Given this list of marker genes Syp, Gabrg2, Pax8, Mir26a-2, Cacna1e, Lnpep, Bmp6, Ywhaz, Dab2, Hes1, Rbm4, Chrnd, Glra2, Mir125b-1, Slc16a2, Cck, Tshz3, Mir153, Entpd1, Mir15a, Cyp46a1, Syt6, Tenm2, Gria2, Oxct1, Pdlim4, Agtr1a, Ophn1, Lypd1, Agtr2, Pde4a, Cdh2, Plcd1, Midn, Shank3, Grm1, Sytl4, Slc12a5, Fcer1a, Hnf4a, Rasgrf1, Gata3, Mir301b, Mir28a, P2rx7, Cacna2d1, Dlg3, Ghrh, Myb, Wnt7a, Wnt5b, Lgals3, Lyn, Fkbp1b, Egfr, Cacna1a, Insyn1, Dgat1, Syngr3, Mup2, Gpr158, Agrn, Lin7c, Dvl1, Asic1, Lrp5, Prkce (protein kinase C, epsilon), Tbc1d1, Snap47, Hrh2, Slc30a8, Selenom, Lrfn2, Gabrg1, Mir501, Gdf9, Mir667, Pacsin2, Rims4, Btk, Ptpn23, Tbx3 (T-box 3), Ncoa6, Gata1, Homer3, Pink1, Synpo, Dkk1, Tacr1, Gprin3, Sncg (NCBI Gene Id 30871), Ptprn (NCBI Gene Id 19275), Psca, Sh3gl1, Igfbp3, Mir204, Bsn, Nr4a1, Dlgap4, Rnf167, Atp5pf, Nadk, Pirb (NCBI Gene Id 18733), Mir125b-2, Lrp1, Gal, Cacnb1, Hip1, Drd5, Fxr1 (FMR1 autosomal homolog 1), Plcb4, Arrb2, Rab11fip1 (RAB11 family interacting protein 1 (class I)), Apba1, Clock, Jagn1, Mir328, Abi1 (NCBI Gene Id 214715), Cdc20, Vip, Slc6a4, Brsk2 (NCBI Gene Id 75770), Cspg5, Gabrr1, Nxph4, Pde1c, Efnb3, Mir26a-1, Efna5, Crhbp, Ptprn2, Mafa, Hfe, Plcl1, Npy, Ren1 (renin 1 structural), Fgfr2, Slc1a1, Dlgap1, Kcnj6, Lrrk2, Il1rn, Mir872, Kat2a, Napb, Mir30e, Itpr1, Best1, Tac1, Afdn, Arid1b, Fam3b, Cpeb3 (cytoplasmic polyadenylation element binding protein 3), Gpr151, Cxcl12, Cacng3, Chrna1, Kcnq3, Zdhhc12, Micu3, Ptpn11, Cit, Fgfbp1, Cav2, Mir22, Gucy1a1, Foxo1 (NCBI Gene Id 99758), Stab1, Chrna4, Acvr2b, Rptor (regulatory associated protein of MTOR, complex 1), Chrm1, Gsk3b, Gja4, Cacna1c, Prrt2 (NCBI Gene Id 69017), Eif4ebp2, Creb1, Lama2, Map2k6 (mitogen-activated protein kinase kinase 6), Sirt3 (sirtuin 3), Cep89, Gna11, Snx19, Ly6g6e, Npy2r, Ank2, Vdac3, Atf4, Nrn1, Atxn1, Mir875, Stac3, Ly6g2, Anxa5, Ly6c1, Pdyn, Nkx6-1, Stxbp2, Plppr4, Nxph1, Bmp2, Slc29a1, Trim9, Oprk1, Usp8, Hcar2, Rfx3 (NCBI Gene Id 320548), Grm7, Zbed6, Slc6a5, Nrxn3, Chrnb2, Cacng7, Blk, Mir129-2, Stx1b, Pomc, Irs1, Drp2, Ptpra, Nat8l, Sirt4, Hnrnpk, Mir30b, Zzef1, Gls, Cbln4, Git1, Kcnma1, Mir30d, Ezh2, Chd7, Lhx5, Rnf10, Grik2, Stau2, Stxbp1, Drd1, Abl1, Syngr1, Pfkfb2, Htr1f, Stx4a, Adora1, Ntsr1, P2rx2, Fbxl20, Gabrg3 (gamma-aminobutyric acid type A receptor, subunit gamma 3), Gnaz, Mir124-2hg, Gabrr2, Shisa9, Mir384, Mecp2, Tbx5, Faah, Stxbp3 (syntaxin binding protein 3), Fjx1, Bhlha15, Rap1a, Ghsr, Slc16a1, Slc16a10, Htr5a, Cyp19a1, Chrna7 (cholinergic receptor, nicotinic, alpha polypeptide 7), Snapin, Mir187, Cask (NCBI Gene Id 236691), Gja1, Hmga1, Slc24a1, Lrp6, Ly6f, Pde9a, Nppa, Neto1, Lif, Gip, Vps35, Stx19, Ephb1, Lin7b, Nptn, Chrm2, Trpv6, Adra1b, Barx1, Kif1b, Cntn2, C1qtnf12, Notch1, Mir484, Cxcl13, Tmod2, Clstn1, Slc25a22, Gabrb3, Rab8a, Cyp27b1, Cdh8 (cadherin 8), Rims3, Bcr, Mir138-1, Pask, Gjc2, Tmem108 (NCBI Gene Id 81907), Gpr68, Penk, Mir19b-1, Syt9 (synaptotagmin IX), Ptges, Kalrn, Chrnb1, Slc24a2, Ntf3, Cftr, Eif2ak4, Rph3al, Eny2, Htr1d, Mir760, Mir130a, Dtnbp1, Gipr (NCBI Gene Id 381853), Efr3a, Cacng2, Shisa6, Mir467a-3, Scrib, Bad (NCBI Gene Id 12015), Eipr1, Pten, Zmynd8, Ano1, Rab5a, Grid1, Mir150, Slc30a1, Cyth1, Slc12a2, Cartpt, Ube2q1, Mpc2, Chrna5, Adgrb1, S100a8, Kctd13 (NCBI Gene Id 76489), Nos2, Mfn2, Pfkm, Trpm4, Rgs8, Grin2b, Pde4c, Rac3, P2ry2, Ptgs2, Grem1, Tcirg1 (T cell, immune regulator 1, ATPase, H+ transporting, lysosomal V0 protein A3), F2, Rph3a, Septin5, Epha5, Fzd4, Mir381, Mir92-1, Cckar, Gnao1, Cplx1, Phf24, Cnrip1, Abcg1, Grm3 (NCBI Gene Id 70346), Ywhah, Ednrb, Mir145a (NCBI Gene Id 387163), Mir24-1, Sorcs2, Lepr, Spg11, Npas4, Bcas3, Myt1, Adrb1, Ntng1, Myrip, Fzd1, Scg5, Cln3, Glra3, Il1rapl1, Camkv (CaM kinase-like vesicle-associated), Dnm1l, Mup1, Lgmn, Htr1a, Rimbp2, Kcnn4, Stxbp5, Tbc1d24, Hrh1, 2610042L04Rik, Mc4r, Nos1 (nitric oxide synthase 1, neuronal), Edn3 (endothelin 3), Gdnf, Osbp (NCBI Gene Id 76303), Runx1, Cacnb2, Ppt1, Edn2, Sirt6, Ror2, Ptk2, Sct, Lhx1, Crhr2, Sipa1l1, Epha7, Pla2g3, Alg13, Per2, Bcl2l1, Mirlet7c-2, Gja8, Cry2, Mir124a-1hg, Gpr27, Cckbr, Mir30c-2, Pak1 (NCBI Gene Id 18482), Lzts1, Porcn, Mctp1, Als2, Kcne5, Prkar1b, Lynx1, Tcf7l2, Mir378a, Ncam1, Gjd2, Mir1983, Nmu, Cplx4, Htr3a, Gabbr1, Mir374b, Gjb6, Bche, Rapgef2, Bace1, Shc3, Gabra5, Mirlet7e, Crtc1, Rab3a, Ptbp1, Lrrtm2, Mir425, Neurl1a, Usp14, Mme, Gabra2, Ihh, Mlxipl, Btbd9, Slc1a7 (NCBI Gene Id 242607), Wnt3a, Aimp1, Grin2d, Htr2a (NCBI Gene Id 239184), Glrb, Mapk8, Egr1, C1qtnf3, Erbb4, Hif1a, Mir324, Kcnip1, Ngfr, Adora2b, Trpv1, Psmc5, Acp4, Snord33, Tprg1l, Akap12, Slc4a8, Egr2 (early growth response 2), Ncdn, Mir467b, Mup11, Trpa1, Sox11, Lamp5, Hapln4, Cpeb1, Fcgr3, Usp46, Mir23b (microRNA 23b), Mir382, Map1b, Eif4e, Cyb5r4, Hoxa5, Mir487b, Nisch, Cdk5, Cfl1, Fgf9, Eea1, Sri, Lrrc4, Ppp3cb, Tm2d3, Wls, Rims1, Pianp, Ina, Igsf21, Ntf5, Ptpmt1, Cdh1, Ffar2, Kcnb1, Mir541, Nrxn1, Slc7a10, Elfn1, Foxl1, Grin3b, Mir99a, Cdh11, Fgfr3, Ggcx, Pex5l, Plk2, Sv2a, Iqsec1, Srf, Neto2, Mir467a-9, Serp1, Mir434, Mir138-2, Mir149, Ptk2b, Cdk16, Mir551b, Htr7, Car2, Ntng2, Cadm1, Myo5b (NCBI Gene Id 383414), Calb1, Smad4, Gje1, Ccr1, Stim1, Mapk8ip2 (NCBI Gene Id 97995), Akap5, Lrp8, Bmp4, Rapsn, Dgke, Htr3b, Atp1a3, Mapk1, Atg5, Dynll1, Sirt1, Kcnk2, Kcnj8 (potassium inwardly-rectifying channel, subfamily J, member 8), Gjb5, Pcdh8, Nr2e1, Itgb1, Grin2a, Ucn3, Ncstn, Mir211, Gnas, Pdzd11, Retn, Mir467a-10, Nr0b2, Slc8a3, Vamp2, Ifng, Mir320, Wnt11, Gjc1, Aph1c, Mir19a, Ppp3ca, Rab3gap1, Gja5, Fchsd1, Gsg1l, Fto, Slc38a1, Adcy5, Chrna6, C1qtnf1, Dhh, Fgf7, Edn1, Chrnb4, Nup155, Ly6g, Niban2, Snap29 (synaptosomal-associated protein 29), Fyn, Kcnd3, Tfap2b, Rasd2 (NCBI Gene Id 75141), Mir540, Il1a, Fgfr1, Npvf, Ston2, Pfn2, Kpna1, Syt11, Map4k4, Syk, S100a9, Cacnb4, Anxa1, Begain, Mir106b, Fbxo41, Fam107a, Rtn4, Slitrk5, Ly6i, Ndufaf2, Thy1, Syt3, Inhba, Syn1, Cnr2 (cannabinoid receptor 2), Kcnq4, Adcy1, Etv5, Mir421, Uts2, Glp1r, Mir106a, Tm7sf3, Snord35a, Mir19b-2, Mir101a, Maob, Pmch, Nell2, Sox4, Drd4, Scn4b (NCBI Gene Id 399548), Dlgap2, Htr4, Drd2 (dopamine receptor D2), Stx11, Grk2, Xlr4b, Mir9-2, Mir221, Prkca, Cxadr, Sqstm1, Tgm2 (NCBI Gene Id 21817), Cacna2d2, Abtb3, Kras, Wnt10b, Sucnr1, Eif4a3l1, Snap25, Cplx3, Nr1h4, Syde1, Cgas (NCBI Gene Id 214763), Prkcb, Ccn3, Slc4a10, Crhr1, Star, Wnt9b (wingless-type MMTV integration site family, member 9B), Myh9, Osbpl2, F2rl1, Lep (NCBI Gene Id 16846), Gabrd, Oprm1, Slc8b1, Celf4, Mir181b-1, Grid2ip, Acvr1c, Htr1b, Ptn, Irs2, Vamp8, Dcdc2a, Farp1, Smad2, Fgg, Mir345, Sncb, Mup4, Pfkl, Ckap5, Scn1b, Insyn2a, Cpt1a, Dagla, Ffar4, Ptgs1 (prostaglandin-endoperoxide synthase 1), Ghrhr, Srebf1, Sptbn2, Grp, Doc2g, Mir181d (microRNA 181d), Mir92-2, Stat3, Cacng8, Cabp1, Doc2a, Tardbp, Gja3, Mir9-1, Plcg1, Shisa7, Pim3, Ccr1l1, Dlg1, Clstn3, Plg, Arhgef7, Bdnf, Gabra4, Exoc3l, Pxk, Inha, Gabra3, Slurp2, Adarb1, Mir24-2, Nrgn, Cd68, Dbn1, Fbn1, Syt1, Unc13b, Mir652, Rasgrf2, Crkl, Mir770, Mir26b, Pdgfa, Galr1 (NCBI Gene Id 14427), Cnih2, Kcnn2, Napa, Lypd6, Adra1a, Grik5, Chrd, Cnr1, Gpnmb, Kpna4, Ucn, Syt5, Syt8, Mir29a, Reln, Abca1, Elfn2, Gjb4, Sv2c, Rgs14, Npy1r, Dytn, Neo1, Dlg4, Clcf1, Slc17a7, Wnt8b, Pkp2, Ctbp2, Gpr119, Uqcc2, Pvalb, Ryr2 (ryanodine receptor 2, cardiac), Kcnk9, Sh2d1a, Smo, Gpr156, Mir218-1, Mctp2, Chrna3, Htt, Flna, Snx14, Rnf216, Nppc, Mapt, Tpbg, Slitrk3, Apba3, Ly6h, Gja10, Cx3cr1, Akap7, Chrng, Erc1, Snord32a, Fgf2, Cntnap4, Slc38a2, Ssh1, Ly6e, Grik4, Chrdl1, Kcnj5, Fgfbp3, G6pc2, Ptpn5, Cacna1d, Dio2, Synpr, Raf1, Drd3, Wnt2b (wingless-type MMTV integration site family, member 2B), Dmd, Nlgn1, Psen2, Nrg1, Capn10, Kcmf1, Fbxo2, Sidt2, Gjb3, Pth, Atp2b2, Rfx6, Igf1, Mir29b-1, L1cam, Plcl2, Cplx2, Nf1, Pafah1b1, Aacs, Sv2b, Stxbp5l, Rasl10b, Gata4, Kif5b, Tnfsf11, Arf1, Crh, Mir467a-2, Doc2b, Chat, Camk2d, Sstr5, Nrxn2, Gabrb2, Wnt2, Nfatc4, Htr5b, Pnoc, Dmxl2, Tacr2, Cd24a, Rin1, Mirlet7i, Cpe, Cacnb3, Mir410, Tbx18, Nr3c1, Ube3a, Grin1, Grm2, Mir7-1, Sorbs1, Sez6, Abcc4, Lrrtm1, Prrt1, Mir25, Pde3b, Gck, Atad1, Fcgr2b, Osm, Rab3b, Mirlet7f-1, Vgf, Rara, Nrg3, Fmr1, Oxt, Abhd6, Ncs1, P2rx3, Wnk4, Slc5a7, Plcb1, Mir379, Grik3, Htr2c, Park7, Fcer1g, Slc12a6, Ppfia3, Glra4, Alox5, Pla2g4a, Nr3c2, Slc6a6, Psen1, Or51e2, Tspoap1, Mir467a-8, Grm5, Pdx1, Adra1d, Cbln1, Ly6g6g, Snap23, Dmpk, Mir337, Unc13c, Kcna5, Npff, Chrm4, Shank1, Fam3d, Ythdf1, Cry1, Ly6g6d, Itpr3, Pate6, Rangrf, Pfn1, Baiap3, Mef2c, Syngap1, Prr7, Plat (NCBI Gene Id 51950), Myo6, Lrrc8a, Lgi1, Grm4, Gper1, Slc6a2, Slc1a3, Jph4, Tnfrsf1b, Met, Hadh, Prkd1, Aldh5a1, Trpm2, Prkcz, Ext1, Chrne, Wnt6, Nsmf, Ntrk1, Tubb2b (tubulin, beta 2B class IIB), Jph3, Fzd2, Hnmt, Rps6kb1, Rab11b (RAB11B, member RAS oncogene family), Foxl2, Rimbp3, Scn3b (sodium channel, voltage-gated, type III, beta), Ptprv, Syn2, Exoc4, Gnai2, Cntnap2, Adora2a, Panx2, Syt7, Mir672, Mir128-2, Sphk1, Dscam (DS cell adhesion molecule), Hilpda, Nefh, Ccr2, Sorbs2, Nlgn3, Slc12a7, Pick1, Grip1, Hrh4, Mdm2, Gpld1, Nkx3-1, Trpm5, Ptprd, Ppp3r1, Zdhhc2, Adcy8, Ucn2, Ecrg4, 2510002D24Rik, Panx1, Mir125a, Camk2a, Wnt3, Aqp1, Kpna2, Git2, Chga, Nnat, Kcnj11, Wnt1, Cacna1b, Gcg, Gprc6a, Spp1, Ctnnd2, Isl1, Sncaip, Mpp2, Mirlet7c-1, Rapgef4, Tsc2, Prkar2b, Ildr2, Nlgn2, Synj1, C2cd2l, Gjb2, Mir433, Bglap, Mir181a-1, Erc2, Lin7a, Xbp1, Gabre, Mir467a-1, Mapk3, Cc2d1a, Hmgn3, Itsn1, Unc13a, Mir369, Mir222, Rest, Zdhhc17, Anapc2, Ildr1, Ica1, Slc2a2, P2ry1, Clcn3, Rab11fip3, Pdgfb, Vps54, Musk, Paip2, Ngdn, Snord34, Pate4, Slc44a4, Cyfip1, Mtmr2, Gria3, Npr2, Dnm1, Shank2, Hdac6, Ngf, Igf1r, Mir467a-4, Mir300, Kdr, Ccdc186, Mir218-2, Rab11a, Car7, Shisa8, Mir20a, Mir148b, Hnf1b, Ccl2, Neurod2, Kmt2a, Rgs4, Syap1, Hgf, Mir539, Rac1, Scn5a, Igsf9b (NCBI Gene Id 407794), Adra2a, Camk2g, Dll1, Fgb, Igsf8, Arrb1, Cela2a, Camk4, Mir467a-7, Vsnl1, Ntrk2, Grm8, Tnfrsf11a, Grik1, Gpr39, Rab44, Slc6a9, Nr1d1, Mir195a, Trio, Nsg1, Anks1b, Ptchd1, Il6, Dtnb, Gria1, Clstn2, Sorcs3, Adam17, Comt, Tyrobp, Kcnc3, Mylk2, Dgki, Apba2, Kcnc4, Ephb2, Mir129-1, Il1b, Foxa1, Mmp9, Abcc8, Adora3, Bmal1, Orai1, Iqsec2, Prkar2a, Rgs10, Fchsd2, Igsf11, Prnp, Camk2n1, Gjb1, Aph1b, Slc18a3, Cd300a, Grin2c, Mir383, Htr2b, Gria4, Mup3, Mirlet7f-2, Grm6, Map1a, Mir137, Rbp4, Egr3, Mir200a, Hras, Rab3gap2, Mif, Myo5a, Vamp1, Tnr, Stx1a, Agt (NCBI Gene Id 11606), Abca12, Slc9b2, Fga, F2r, Cadps (Ca2+-dependent secretion activator), Cd38, Kcnj10, Kcnh1, Nps, Hnf1a, Gfap, Mir673, Fabp5, Adcyap1, Gabbr2, Pla2g10, Panx3, Mir181a-2, Otof, Anxa9 (annexin A9), Sctr, Gjc3, Tmem25, Neurod1, Cd2ap, Cga, Sybu, Tent2, Trpv4, Mir132, Syt10, Bglap2, Vdac1, Apoe, P2ry12, Mir467a-6, Pla2g6, Slc6a1, Chrna9, Ucp2, Arc, Nefl, Klf5, Madd, Ltbp4, Tmem132a, Wnk1, Hap1, Camk2b, Dlgap3, Gabrq, Mir7b, Npy5r, F2rl2, Gipc1, Rab11fip5, Grid2, Rims2, Kiss1, Mir126a, Xlr4a, Trp63, Serpine2, Trh, Cx3cl1, Cnih3, Brsk1 (BR serine/threonine kinase 1), Syn3, Prepl, Gnal, Lrit1, Selenot, Mir330 (NCBI Gene Id 724063), Disc1, Mir128-1, Mycbpap, Mir744, Nfe2, Dcc, Cdk5r1, Mir98, Frrs1l, Kcna2, Mcu, Chrna2, Enpp1, Mgll, Cd34, Fgf23, Kdm5b, Cacng4, Chrm3, Tfr2, Mir101b, Inhbb, Tiam1, Flot1, Ereg, Kcnq1 (NCBI Gene Id 547397), Cntf, P2ry4, Rab11fip2, Mir181c, Chrnb3, Mir29b-2, Psmd9, Nucb2, Chrm5, Dtna, Cux2, Kcnq2, Pgr, Cacng5, Glud1, Mir134, Ccr5, Fbxo45, Ccl8, Slc17a8, Ppp1r9a, Epha4, Stxbp4, Slc17a6, Mapk9, Adipoq, Gm5849, Baiap2, Piwil4, Mtor, Mir92b, Glra1, Trpc1, Slc12a4, Gnai1, Th, Mir181b-2, Cdkl5, Dlg2, Ctnnb1, Kiss1r, Fgf14, Htr6, Pclo (NCBI Gene Id 26875), Foxa2, Oga, Sfrp1, Cpeb2, Nog, Gabra1, Nodal, S100b, Mink1, Kmo, Pck2, Mir23a, Slitrk4, Calhm2, Mir93, Ensa, Ly6m, Glul, Nedd4, Acvr2a, Jak2, Smpd3, Ube2i, Snx4, Rela, Chmp2b, Ptger4 (NCBI Gene Id 19219), Fgf12, Tmf1, Mir467a-5, Clmp, Foxd1, Rab1a, Slc8a2, Scn10a, App, Celf6, Mir151, Wnt10a, Rhot1, Hmgcr, Ager (NCBI Gene Id 11596), Pcp4, Birc5, Hmga2, Mir30c-1, Ppard, Mir338, Cbln2, Nlgn4l, Gabrb1, Snca, Itsn2, Hcn4, Mir7-2, Braf, Gabra6, Ccl5 (NCBI Gene Id 20304), Mir191, Adam8, Mir127, Ptprs, Rab8b, Casr, Wnt5a, Tnf, Cacna1g (NCBI Gene Id 12291), Vps13a, Fxr2, Hrh3, Shh, Ppfia2, Fgf22, Dgkb, Tnc, Slc18a2, Dbi, Anxa7, Ncan, Mir342, Oxtr, Fgfr4, Mir500, Vdr, Mir100, Prkaca, Eif4a3, Grip2, Abr (NCBI Gene Id 11357), Gnat1 (NCBI Gene Id 14685), Ache, Ly6a (lymphocyte antigen 6 family member A), Large1, Lrrc4c, Hcfc1, Prkcg, Tspo, Ly6c2, Nmb, Pde8b, Il11, Ffar3, Acsl4, Oprl1, Zdhhc3, Gja6, P2rx6, Mir411, Mir674, Vps18, Slc18a1, Mir30a, Klf7, Prkn, Homer1, Fam3a, Gnaq, Stx3, Ace, Mup5, Ric3, Gjd4, Prkar1a (protein kinase, cAMP dependent regulatory, type I, alpha), Tor1a, Lrit3, Mir486, Kit, Chrna10, Itpka, Adnp, Ffar1, Dag1, Ghrl (ghrelin), Mir17, Utrn, Atg7, Tunar, Rnf19a, Pnkd, Syt13, Fgf10, Cyp2j5, Mtnr1b, Ywhag, Eif4a3l2 (eukaryotic translation initiation factor 4A3 like 2), Grin3a, Stau1, S1pr2, Mirlet7d, Arhgap44, Snap91, Tpgs1, Rap1b, Hcrt, Ccl3, Syt12, P2rx4, Syt4, Cltrn, Slc7a11, Apln, Syt2, Wnt4, Nalcn, Il1rap, Gjd3, Pparg, Cadps2, Mtnr1a, Abat, Mir9-3, Ptger3, P2rx1 (purinergic receptor P2X, ligand-gated ion channel, 1), Pcdh17, Adrb2, Stx2, Atp2a2, here is a description of the gene set: Any process that mediates the transfer of information from one cell to another. This process includes signal transduction in the receiving cell and, where applicable, release of a ligand and any processes that actively facilitate its transport and presentation to the receiving cell. Examples include signaling via soluble ligands, via cell adhesion molecules and via gap junctions. species: Mus musculus Mouse Gene Set: GOBP_CELL_CELL_SIGNALING